The following is a description of a gene set: studied in species Homo sapiens Sparse lateral eyebrow Human Gene Set: HP_SPARSE_LATERAL_EYEBROW Decreased density/number and/or decreased diameter of lateral eyebrow hairs., and this is the list of marker genes: KMT5B, CDC42BPB, LIG4, LPAR6, KDM6A, ATR, PURA, PIGK, MESD (mesoderm development LRP chaperone), COG6, NSUN2, WLS, KRT74 (NCBI Gene Id 121391), MAN1B1, TWIST2 (twist family bHLH transcription factor 2), IRX5, TBX3, NECTIN1, H4C5, LMBRD2, TRPS1, HNRNPK, LIPH, EDARADD, PQBP1, KDF1, KMT2D, PPP1CB, WDR26, PIGL, KAT5, HEPHL1, USB1, KRT25, PLXNA1, KRT71